The following is a description of a gene set: studied in species Homo sapiens Pathway Definition from KEGG: SIGMAR1* -> ITPR -> Ca2+ -- MCU -> Ca2+(mito) -- MPTP -> CYCS Human Gene Set: KEGG_MEDICUS_VARIANT_MUTATION_INACTIVATED_SIGMAR1_TO_CA2_APOPTOTIC_PATHWAY Mutation-inactivated SIGMAR1 to Ca2+ -apoptotic pathway. Pathway ID: N01151. Pathway type: Variant. Pathway class: nt06464 Amyotrophic lateral sclerosis., and this is the list of marker genes: ITPR2, ITPR1, ITPR3, SLC25A6, VDAC1, SLC25A5, SLC25A4, MCU, SIGMAR1, VDAC3, VDAC2, SLC25A31, CYCS